Given this list of marker genes PPP1R3F, CCNT1, AMER1, DZIP1, RCAN3, WASL, PHF2, PATJ, SAMD8, FOXO1, USP12, LFNG, ENPP4, NRIP3, ZFP36L2 (NCBI Gene Id 96706), PLCB2, AAK1, LARP1, NR3C1, KLF7, BRWD1, TIPARP, CTDSP1, TNRC6B, ARHGAP35, GM2A, LRRC39, PNRC1, TTC3, SENP6, RAD52, MCMBP, IRAK3, RPLP1, XPO4, ELOVL7, IL27RA, CLCN6, CREBL2, SULF2, BZW2, POU5F2, S1PR1, NFRKB (nuclear factor related to kappaB binding protein), TRIO (NCBI Gene Id 7204), PATZ1, TMEM64, FOXP1, ATP1B1, BRD3, PPP1R3B, PDE4B, PPM1L, DENND11, NR1D2, CDADC1, RTCB, IBTK (inhibitor of Bruton tyrosine kinase), PADI2, MPPE1, CNST, CEBPZ, INSR, IL7R, PAG1, ZNF569, WTAP, TFAP4, AMPD3, CD302, DIPK1A, TBXA2R, CLPP, ATN1, SUCO, FOXO3, VPS37B, CNOT1, TCP11L2, AFG2B, LZTFL1, TXNIP, DDX3X, SNHG8, SMAD4, ADD3, AMPD1, DENND2C, RALGPS2, RAMP1, PEX19, SLC49A4, GPR146, SERINC4, ZNF263, BCL9, RACK1, RPS14, ALG2, RNF220, SGK3 (NCBI Gene Id 23678), IQGAP2, PIK3IP1, TSC22D3, BRAF, RPL9, PACC1, ARID4B, YAE1, MOSMO, PPARGC1B, FAM78A, KMT2E, LYNX1, PFKFB2, ZRANB1, HSDL1, TMEM71, RNF167, SLF2 (SMC5-SMC6 complex localization factor 2), ZNF281, SERAC1, TCEANC2, ZNF652 (NCBI Gene Id 22834), PRPF6, ICAM2, SLFN13, SLC25A2, LCOR, PTK2, DCUN1D3, SLC5A10, SKI, WDR20, ATXN1L, ZBTB37, USP32, CLCF1, CNN3, IRF2BPL, L3MBTL3, RC3H1, RGMB, TRMT13, LRIG1, ZBTB4, LYPD6B, NFE2L3, SELL, PPM1B, MICALL1 (MICAL like 1), CCR7, LETM2, DNAI4, ADD1, IFT80, SHE, PTPN18, GATAD2B, WDR37, TNKS (NCBI Gene Id 8658), PJA2, TRIB2, GLRA4, GALNT6, FNDC10, DYRK2, HECTD2, CHD7, SKIL, ARL4C, USP50, CFL2, RTN4RL1, EPM2AIP1, NEXN, KIAA0930, ACSS1, SMARCA2, SRRM2 (NCBI Gene Id 51462), ART4, LRRIQ4, SULT1A1, LDHB, PPRC1 (PPARG related coactivator 1), MCL1, ARRDC3, PCIF1, RFTN1, RPS19, CARD6, ZDHHC17, ST8SIA1, SNX31, BACH2, IGIP, FILIP1L, SCML4, MINDY2, DDX50, here is a description of the gene set: T follicular helper (Tfh) cells play a pivotal role in germinal center reactions, which requires Bcl6 transcription factor. To analyze their relationships with other effector T cell lineages and their stability in vivo, we developed and analyzed a new Bcl6 reporter mouse alone or together with other lineage reporter systems. Assisted with genome-wide transcriptome analysis, we show substantial plasticity of T cell differentiation in the early phase of immune response. At this stage, CXCR5 appears to be expressed in a Bcl6-independent manner. Once Bcl6 is highly expressed, Tfh cells can persist in vivo and some of them develop into memory cells. Together, our results indicate Bcl6 as a bona fide marker for Tfh polarized program. Human Gene Set: GSE40068_CXCR5POS_BCL6POS_TFH_VS_CXCR5NEG_BCL6NEG_CD4_TCELL_UP studied in species Homo sapiens from publication Liu X, Yan X, Zhong B, Nurieva RI, Wang A, Wang X, Martin-Orozco N, Wang Y, Chang SH, Esplugues E, Flavell RA, Tian Q, Dong C (PMID 22987803) Genes up-regulated in CXCR5+ BCL6+ follicular helper T cells versus CXCR5- BCL6- CD4+ T cells.